The following is a description of a gene set: from publication Chen Y, Wang X (PMID 31504780) Human Gene Set: MIR3927_5P species: Homo sapiens Genes predicted to be targets of miRBase v22 microRNA hsa-miR-3927-5p in miRDB v6.0 with MirTarget v4 prediction scores > 80 (high confidence targets)., and this is the list of marker genes: OS9, MIB1, LIN7C, WNK1 (NCBI Gene Id 9872), GRIN3A, ZNF233, FRK, HCAR3, AHCTF1, PAM, ETAA1, PLEKHA8, HCAR2, MSI2, ZNF75D, EPB41L5, VOPP1, CECR2, NDEL1, NPM1, GJB7, JPT2, KLK2, FZD2, KBTBD8, FUBP1, CDKL5, POU2F1, ZKSCAN3, NEMF, PCDHB16, ADAMTS1 (ADAM metallopeptidase with thrombospondin type 1 motif 1), DBN1, TRAF3, CEP43, TMLHE (trimethyllysine hydroxylase, epsilon), ATP6V0A2, TM4SF18, ABTB3, DAPK1, CLCN3